Given this list of marker genes CILK1, CHD2, TUBB2B, SCN1A, CPA6, PCDH19, SLC9A6, GABRA1 (gamma-aminobutyric acid type A receptor subunit alpha1), SCN9A, CLCN2, GABRD, KCTD7, KCNQ3 (NCBI Gene Id 3786), EFHC1, TUBB3, GABRG2, SCN1B, SCN2A, CACNB4, JRK, SYNGAP1, TUBA1A, here is a description of the gene set: Seizures precipitated by exogenous stimuli. Human Gene Set: HP_REFLEX_SEIZURE studied in species Homo sapiens Reflex seizure